Given this list of marker genes GAD1, AMPH, NEUROD2, OXT, MIR30B, NPTX2, GHSR, C22orf39, EPHA4, HTR1A, SYN3, TRIO, INSYN2A, CHRM3, GRM3 (glutamate metabotropic receptor 3), CCL2, DNAJC5, GSK3A, KCNC4, ZDHHC12, SNAP29, HRH1, RIMBP2, S100B, ADGRB1, CREB1, ABHD6, RPS6KA3, ALS2, LRIT3 (leucine rich repeat, Ig-like and transmembrane domains 3), NF1, RIC3, PTPRD, STAU1, HOMER1, TNR, INS, TMEM108, USP14, RNF167, PRKCE, SLC24A1, CHRNE, CLCN3 (NCBI Gene Id 133073), NSMF, HTR5A, STX19, RAP1B (NCBI Gene Id 5908, RAP1B, member of RAS oncogene family), PDE9A, HCRT, SYT3, KCNN1, STX3, GABRA4, CX3CL1, RGS14, NEURL1, ITPR3, JPH3, NR2E1, FBXL20, GIPC1, RIT2, PNKD, PVALB, BACE1, NEO1, BRSK1, NEFL, CDK5 (cyclin dependent kinase 5), AP2B1, SLC4A8, CALB2, MIR433, LPAR3, SYPL1, KCNMB4, SLC8A3, USP46, VAMP2, ADIPOQ, VPS35, NTF4, GABRA1, GRM1, KIF5A, DRD5, KCNIP1, ELFN2, LILRB2, CCR2, RGS10, RELA, AKAP12, CNTN4, RASD2, CNTNAP4, SYP, EFR3A, PLK2, STXBP3, HTR2A, CACNA1B, ADNP, MIR421, USP8 (NCBI Gene Id 9101), SYT4, RAP1A, SYT7, UTRN, SLC17A7, MCTP2, TRPV1, MAPK8IP2, KIF1B, ATAD1, NAPB, DMD, GLS, SYNGR1, SLC5A7, PCDHB4, MYOF, PFN1, HAP1, SYT12, CPLX4, BAIAP3, KCNQ3, SLC38A2, KCNK2, RAP1BL, GNA11, PICK1, KCTD13, LGMN, GRID2, KIT, DLGAP1, FBXO45, MECP2, STAC3, CALM1, RPS6KB1, INA, SLC30A1, CHRNA2, SLITRK5, BCHE, OPHN1, NOG, P2RY1 (purinergic receptor P2Y1), UTS2, BDNF, CALM3, BGLAP, UCN, SLC6A6, GPER1, GRIK5, BSN, GRIN3B, TYROBP, TPRG1L, PLPPR4, PCDHB14, SYT11, HDAC6 (histone deacetylase 6), CLMP, NLGN1, CFL1, CHRNA3, AKT1, NRXN2, AKAP9, SORCS3, GRIK4, LAMP5, CTNNB1, CNRIP1, GABRD, BAIAP2, F2R, MTNR1B, CAMK2D, STX2, VDAC3, ETV5, EIF4A3, GDNF, COMT, CAMK2G, LRP8, ABCC8, PHF24, PLAT, SLC6A3 (solute carrier family 6 member 3), CD2AP, FAAH, LRRTM1, GRM8, FGF12, SQSTM1, PLP1, FCHSD1, WNT7A, SEPTIN5, CACNG4, PTCHD1, ADARB1, NTNG2, GRID1, DYSF, ATF4, MIR95, RELN, DCC, ARRB2, ZDHHC2, CDK5R1, DRD1, NPAS4, TSHZ3, GRID2IP, ADCY1, PCDHB13, MET, LRFN2, SLC7A10, NPBWR1 (NCBI Gene Id 2831), ADRA2A, HTR3B, PDYN, NPR2, VGF (NCBI Gene Id 7425), CDH8, PMP22, BCR, CHRNA6, HRH2, MIR142 (NCBI Gene Id 406934), DRD4 (NCBI Gene Id 1815), CHRNB1, NTF3, LRRC4, CHRNA10, SLURP2, MIR324, STX11, MDM2, CASK, PTN, SORCS2, GALR3, CDC20, SLC18A3, ATP2A2, FARP1, CBLN2, NPY5R, PNOC, KCND2, GNB1, STX4, PTPRN2, SHANK2, ABL1, CACNB3, PRKCG, OMP, MINK1, UNC13B, ADORA2B, MPP2, NPY (neuropeptide Y), GPR151, SLC6A5, SLC1A7, NXPH4, RIMS1 (regulating synaptic membrane exocytosis 1), NRGN, EPHB2, HCN1, OTOF, SRF, ZDHHC3, SV2C, PPP3CB, HTR3A, GABRG1, GUCY1A1, GRM2, KPNA1, RAC1, P2RX1, SLC1A2, SEZ6, UBE3A, JAK2, ATXN1, CHRNA5, LAMA2 (NCBI Gene Id 3908), MPZ, GABRA5, MEF2C, RAPSN, SLC4A10, HIP1, HCRTR1, ABR (NCBI Gene Id 82701), NXPH1, EGR3, DGKE, GLRB, BEGAIN, KCNMB1, SYT8, ATG5, MCTP1, SYT1, DLGAP3, MYCBPAP, RAB11A, KCNJ10, FER1L5, NLGN2, LRRK2 (leucine rich repeat kinase 2), SNAP47, ZMYND8, SHISA6 (NCBI Gene Id 388336), PTEN, OPRK1 (NCBI Gene Id 4986), GRIA4, CALM2, LRRC4C, GABRA2, MICU3, INSYN1 (inhibitory synaptic factor 1), EXT1, P2RX7, SLC1A1, RPS6KA1, ITPKA, PRR7, WNT3A, SYT5, SNCG, GPR158, CHRNB4, ANXA9 (NCBI Gene Id 8416), GNAQ, CACNA1A, NPPA, GLRA2, UNC13C, RGS8, RETN, PCDHB10, LY6E, GRM4 (NCBI Gene Id 2914), RAB3GAP1, PPFIA3, EXOC4, GPRIN3, GRIK2, GABRR1, ARF1, STAT3, EIF4EBP2, LYNX1, DKK1, CDH1, SERPINE2, MYLK2, OPRM1, MME, RTN4, IQSEC2, JPH4, PRKCB, PCDH17, CACNB4, CEP89 (centrosomal protein 89), MBP, GABRR2, DVL1, TACR2, VDAC1, DAGLA, FAM107A, GABBR1, DTNB, SDCBP, GRIA1, KIF5B, DLG4, PCDH8, DRD3, OPRL1, HTR4, GNAI2, GABRA3, PCDHB6, GSK3B (glycogen synthase kinase 3 beta), NRN1, KCNK3, HRH4, DISC1, BTBD9, LIN7A, EIF2AK4, STXBP2, PACSIN2, GABRR3, RIMS3, GRIK1 (glutamate ionotropic receptor kainate type subunit 1), NPS, PPP3CA, DRP2, NRG3, CLSTN3, SLC12A2 (solute carrier family 12 member 2), SNCA, SNX14, CADPS2, CHRM4, CHRNG, GABRG2, SLITRK4, PRKACA, HTR7, SCTR, ACHE, SLC1A4, NTRK2 (NCBI Gene Id 4915), CHMP2B, HTR1B, LIN7C, APBA1, CACNG3, KCNJ8, SLC24A2, HMGCR, PINK1, CAMKV, MIR320E (NCBI Gene Id 100422913), PPP1R9A, SLC17A8, PFN2, CAMK2A, SYT10, CBLN4, NALCN, DLG3 (NCBI Gene Id 89363), CACNG2, GJD2, CHRM1, RAB8A, RPS6KA2, LYPD1, CNTN2, RIMBP3C, CNR1, SLC12A4, SHISA7, HRAS, LZTS1, SPG11, ACP1, ITPR1, MAPT, SNCB, VPS18, CNP, GRK2, SLC12A6 (NCBI Gene Id 9990), P2RX4, DOC2A, VPS13A, PARK7, WNT5A, SYT9, NQO1, PTK2B, NCSTN, TMEM25, CLSTN1, APBA3, PCDHB3, SCT, RPH3AL, PXK, ANAPC2, PPT1, SNAP23, ATXN3, P2RX2, LRRTM2, NFATC4, CADPS (calcium dependent secretion activator), TENM2, ABTB3, RASGRF2, EZH2, PCDHB16, DMPK, HTR6, CLSTN2 (calsyntenin 2), LY6S, CACNG7, NEFH, SLC18A2, CNIH3, BRAF, CARTPT, P2RX5, APOE, CELF4, UNC13A, PTPRS, SLC12A5, EPHB1, YWHAG, NLGN3, CACNA1E, YWHAH, PCLO, APP, CALB1, MIR545, CD38, FBXO2, IL1RAPL1, GRIK3, GABARAP, SIPA1L1, CHRNB2, NPY2R, SNCAIP, GRIA2, PMCH, GRIN2D, UBE2I, MIR320B2 (microRNA 320b-2), BEST1, PSEN1, KCNIP2, DYTN, PPP3R1, ELFN1, TPBG, SHISA9, ALDH5A1, STX1B, PRKAR2B, DTNA, AGER, ADRB2, CNIH2, SLITRK3, CALHM2, LRP6, CDKL5, GIT1, HTR1F, PLCL2, HTR2C, MAPK3 (NCBI Gene Id 5595), GRM6, SLC6A4, RGS4, TPGS1, MAPK1, DLGAP2, VPS54, LARGE1, RAB3B, NTSR1, KCND3 (NCBI Gene Id 3752), SLC1A6, CUX2, EEA1, ASIC1, CHRNA9, CBLN1, SLC7A11, NOTCH1, MIR320C1, EDN1, EFNB3, NTNG1, SLC6A1, NPTX1, CRHR2, DRD2, SYBU, CPEB3, SHISA8, NGFR, FXR1, GNAO1, CACNB2, CYP46A1 (cytochrome P450 family 46 subfamily A member 1), MIR320C2, HAPLN4, GLRA1 (glycine receptor alpha 1), GABBR2, PRKN, GAD2, LRIT1, CA7, RAPGEF2, GRIA3, GRIN2A, LGI1, CRH, HTR1E, SNAP25, CHRFAM7A, TNF, PPFIA2, CPLX1, PRKAR1B, CACNG5, SHANK1, CX3CR1, NOS1 (NCBI Gene Id 4842), FABP5, RIMS4, KMO, STXBP5, CLN3, CHRND, MIR320B1, CAMK2B, TMOD2, PAFAH1B1, ZDHHC17, NETO1, SYN1, SHANK3, SYAP1, CPLX2, CHAT, TOR1A, PLCB1, BLOC1S6, GRIN1, CHRDL1 (chordin like 1), SLC17A6, RAB5A, ITGB1 (NCBI Gene Id 3688), EIF4E (eukaryotic translation initiation factor 4E), RAB3A, CNR2, MIR541, MAPK9, FLOT1, ADORA2A, HCRTR2, KMT2A, KRAS, STX1A, MIR320D1, TSPOAP1, GPR176, NSG1, DTNBP1, LIN7B, PRKCZ, PDE7B, MIR320D2, IL1B, STXBP1, PSCA, TACR1, SV2B, SLC6A9, SYT2, CDH11, SYT13, SLC12A7, AGRN, GRM5, HTR2B, P2RX3, CYFIP1, CRHBP, RNF10, CA2, ARC, FRRS1L, GRIN3A, CACNB1, FBXO41 (NCBI Gene Id 150727), PLG, ATP1A2, FCHSD2, MIR337, DOC2B, HTR3E, GABRE, SV2A, MIR342, MAP1A, GHRL, GGCX, NTRK1, FMR1, YTHDF1, GJC1, SLC32A1, CORT, HTR3D, SCN2B, GRIN2B, GABRB2, COLQ, SYT6, SNAPIN, SYNJ1, PRRT1, ACE, IGSF11, CHRM5, RIMS2, DBH, RIMBP3B, CACNG8, DBN1, GRIN2C, GRM7, EPHA7, IGSF21, PRRT2, SLC38A1, SLC6A2, DLGAP4, PAIP2, DAG1, TUBB2B, DLG1, SSH1, SYNGR3, GABRA6, RARA, NAPA, NLGN4X, PDLIM4, RASGRF1, PIP5K1C, ADORA1, DSCAM, CPLX3, IGF1, OSBPL2, TAC1, UNC119, PENK, SYN2, GLRA3, CHRNA7, NR3C1, RIMBP3, LY6G6D, SCRIB, HTR3C, STAU2 (staufen double-stranded RNA binding protein 2), CHRM2 (cholinergic receptor muscarinic 2), GSG1L, PCDHB11, PMCHL2, NGF, MAP1B, ADCY8, ABAT, APBA2, KAT2A, S1PR2, RPH3A, ADRA1A (NCBI Gene Id 148), SYNGAP1, NPTN, PCDHB2, RAC3, SLC8A2, FXR2, SST, KCNQ2, GABRG3, ERC2, NCDN, CACNA2D2, PCDHB5, KCNB1, RAB3GAP2, HRH3, CHRNA4, PRNP, DLG2, NRXN1, TBC1D24, CRKL, AKAP5, NMU, P2RX6, PDZD11, LY6H, SLC1A3, GFAP, ACP4, AKAP7, GNA15, ADORA3, SLC29A1, CSPG5, IL1RAP, NPFF, PLCL1, PREPL, KCMF1, FYN, CHRNB3, GABRB3, FGF22, MIR320A, MTMR2, ARHGAP44, PCDHB9, CHRNA1, TH, HTR1D, CACNA1G, SNPH, here is a description of the gene set: Human Gene Set: GOBP_SYNAPTIC_SIGNALING species: Homo sapiens Cell-cell signaling to, from or within a synapse.